Given this list of marker genes NOTCH3, TAFA1, BCHE, KCTD11, DLX1, SIX3, ASCL1, DLX2, here is a description of the gene set: Human Gene Set: GOBP_NEUROBLAST_DIFFERENTIATION The process in which a relatively unspecialized cell acquires specialized features of a neuroblast. There are at least four stages through which the pluripotent cells of epiblast or blastula become neuroblasts. species: Homo sapiens